Given this list of marker genes Scn5a, Ank2, Kcna5, Tbx18, Cacna1d, Hcn4, Gja5, Scn3b, Ryr2, here is a description of the gene set: Mouse Gene Set: GOBP_SA_NODE_CELL_TO_ATRIAL_CARDIAC_MUSCLE_CELL_COMMUNICATION studied in species Mus musculus The process that mediates interactions between an SA node cardiomyocyte and its surroundings that contributes to the process of the SA node cardiomyocyte communicating with an atrial cardiomyocyte in cardiac conduction. Encompasses interactions such as signaling or attachment between one cell and another cell, between a cell and an extracellular matrix, or between a cell and any other aspect of its environment.